Given this list of marker genes CDIN1, CLCN7, PKLR, ABCB6, ANK1, GATA1, MTTP, FAS, SPTA1 (NCBI Gene Id 6708), KLF1, HBG1, ADAMTS13, NHLRC2 (NCBI Gene Id 54835), CASK, FASLG, PIGA, SLC2A1, RHAG, CDAN1, CASP10, CPOX, GALE, BCL11A, AMN, SLC4A1, CFHR3, HBG2, G6PD, PFKM, ABCG8, HBB, CFH, PGK1, SPTB, RHCE, UROS, HK1, EPB42, CUBN, EPB41, KCNN4, GCLC, SEC23B, PIEZO1, NT5C3A, CFHR1, RHD, GYPC, here is a description of the gene set: Human Gene Set: HP_RETICULOCYTOSIS An elevation in the number of reticulocytes (immature erythrocytes) in the peripheral blood circulation. Reticulocytosis studied in species Homo sapiens